Given this list of marker genes AP2M1, AP2A1, PCSK9, AP2A2, VLDLR, CLTC, AP2S1, UBA52, UBC, AP2B1, RPS27A, MYLIP, UBB, NR1H2, CLTA, NR1H3, here is a description of the gene set: studied in species Homo sapiens Human Gene Set: REACTOME_VLDLR_INTERNALISATION_AND_DEGRADATION VLDLR internalisation and degradation